Given this list of marker genes FADS6, DPYSL5, OR5K4, C7, EPB41L1, SUV39H2, ABCD2, IL1RL1, CCDC121, H1-6, ZNF180, TRIM6, SLC9A2, FBXW2, PRTG, GHR, NCOA4, TTLL5, MYL10, PNLIPRP2, ADGRA2 (NCBI Gene Id 84863), PDE7B, CENPI, SOX6, RBMY1B, GRIPAP1, MBTPS2, SLC17A1, SCN3A, CSPP1, COL11A1, OLFM4, ARHGEF15, ASPM, RAB34, SIPA1, RACGAP1, FGF13, BGN, TFCP2, here is a description of the gene set: from publication Zheng Y, Valdez PA, Danilenko DM, Hu Y, Sa SM, Gong Q, Abbas AR, Modrusan Z, Ghilardi N, de Sauvage FJ, Ouyang W (PMID 18264109) studied in species Mus musculus Infections by attaching and effacing (A/E) bacterial pathogens, such as Escherichia coli O157:H7, pose a serious threat to public health. Using a mouse A/E pathogen, Citrobacter rodentium, we show that interleukin-22 (IL-22) has a crucial role in the early phase of host defense against C. rodentium. Infection of IL-22 knockout mice results in increased intestinal epithelial damage, systemic bacterial burden and mortality. We also find that IL-23 is required for the early induction of IL-22 during C. rodentium infection, and adaptive immunity is not essential for the protective role of IL-22 in this model. Instead, IL-22 is required for the direct induction of the Reg family of antimicrobial proteins, including RegIIIbeta and RegIIIgamma, in colonic epithelial cells. Exogenous mouse or human RegIIIgamma substantially improves survival of IL-22 knockout mice after C. rodentium infection. Together, our data identify a new innate immune function for IL-22 in regulating early defense mechanisms against A/E bacterial pathogens. Genes down-regulated in ex-vivo colonic tissue after treatment with IL22. Human Gene Set: ZHENG_IL22_SIGNALING_DN